The following is a description of a gene set: from publication Chen Y, Wang X (PMID 31504780) Genes predicted to be targets of miRBase v22 microRNA mmu_miR_299a_5p in miRDB v6.0 with MirTarget v4 prediction scores > 80 (high confidence targets). studied in species Mus musculus Mouse Gene Set: MIR_299A_5P, and this is the list of marker genes: Enpep, Med1, Srsf12, Kcnc2, Eid1, Tnrc6a, Myef2, Tle2, Rassf9, Cep350, Creg1, Smurf2, Wdr26, Fam53c, Lhfpl3, Tssk2, Slk, Fst, Gbp9, Atl2, Nfkb1, Cep55, Ppp3cb, Tceal8, Ebf1, Robo1, Actc1, Ccser2, Entpd7, Vangl1, Ccng1 (cyclin G1), Folr1, Snx12, Calu, Exoc5, Trim31, Sgk1, Loxl3, Slc18a3, Mat2a, Cstad (NCBI Gene Id 78617, CSA-conditional, T cell activation-dependent protein), Mafg, Grpr, Tiparp, Neurod1, Mrpl55, Slco2b1, Fam3c, Zmym5, Zmynd19, Itih3, Tardbp, Ppm1f, Zfp82, Treml2, Cab39, Sp1, A330070K13Rik, Far1, Flvcr2, Anks4b, Bckdha, Man2a2, Zdhhc5, Zfp106, Lyzl6, Acsl1, Neu3, Xkrx, Zfp606, Dido1, Smarcal1, Phyhipl, Slc2a2, Trim29, Hbp1, Sucnr1, Map3k8, Rab3a, Nt5c3b, 4931406C07Rik, Zfand3, Myf6, Rras2 (NCBI Gene Id 97407), Rsbn1, Ddx46, Add2, Spred1, Abr, Dis3l, Minar1, Rora, Zscan18, Tent5c, Zbtb26 (NCBI Gene Id 320633), Lyrm1, Zbtb39, Mapk8, Golga1, Gpatch8, Srsf7, Eln, Gnptg, Ddhd2, Hey1, Siah1a, Ralbp1, Xpr1 (NCBI Gene Id 19775), Mtdh, Stx16, Kdm4a (lysine (K)-specific demethylase 4A), Slc25a3, Cdca4, Setx, Dsc2, Sdad1, Nucks1